The following is a description of a gene set: Genes predicted to be targets of miRBase v22 microRNA mmu_miR_7062_5p in miRDB v6.0 with MirTarget v4 prediction scores > 80 (high confidence targets). from publication Chen Y, Wang X (PMID 31504780) studied in species Mus musculus Mouse Gene Set: MIR_7062_5P, and this is the list of marker genes: Acaca (acetyl-Coenzyme A carboxylase alpha), Shisa7, Trerf1, Lin7c, Nrg4, Rnf130, Raph1, Lyve1, Mrpl15 (mitochondrial ribosomal protein L15), Albfm1, Muc1, Mafk, Srsf2, Tgm6, Zfp92, Mark1, Sprn, Tsbp1, Fos, Pmfbp1, Fndc4, Chd2, Cxcl12, Adam19, Phf21a, Mllt1, Xirp1, Tbc1d24 (TBC1 domain family, member 24), Card10, Ankrd54, Nat8f2, Onecut2, Zscan20, Herc6, Celf2, Stra6l, Xirp2, Spag17, Lmo1, Samhd1 (SAM domain and HD domain, 1), Sorbs3, Mymx, Sdk1, Aak1, Atp8b4, Pcid2, Nkd1, Fam181a, Lrfn4, Oaf, Igf1, Klhl29, Vps37c, Scube1, Atp2a2, Fam83f, Epha2, Kcnj5, Arhgef17, Neu1, Pde6g, Cyp2f2, Eefsec, Rnf38, Hip1, Loxl4, Clrn1, Etnk2, Btbd16, Xrcc3, Hacd1, Stmn4, Agpat4, Nectin3, Tpcn1, Pole4, Actn4, Fiz1, Cnnm1, Them5, Gga1, Smim24, Kctd12, Xkr5, Fam161a, Zfp426, Smyd3, Tmem236, Pax2, Zhx3, Kdm4b, Dgcr8, Ccdc127, Erc1, Pacs2, Gucd1, Mindy4, Bap1, Tbc1d14, Abhd4, Lelp1, Ago3, Kdm2a, Gab2 (growth factor receptor bound protein 2-associated protein 2), Adamts2, Stat3, Cdyl2